The following is a description of a gene set: Mouse Gene Set: GOMF_WW_DOMAIN_BINDING Binding to a WW domain of a protein, a small module composed of 40 amino acids and plays a role in mediating protein-protein interactions via proline-rich regions. studied in species Mus musculus, and this is the list of marker genes: Traf4, Cdc25c, Litaf, Wbp11, Entrep3, Trp63, Ndfip1, Prrg4, Scnn1g, Enah, Shisa5, Wbp2nl, Rapgef2, Pmepa1, Pparg, Dazap2, Nfe2, Scnn1a, Dnm2, Trex1, Kif20b, Wbp1, Tnk2, Ndfip2, Scnn1b